The following is a description of a gene set: Human Gene Set: GOCC_CYTOPLASMIC_LATTICE Fibrous structures of the mammalian ooplasm that store ribosomes and maternal proteins in insoluble form to prevent their degradation, activation and nuclear transfer. studied in species Homo sapiens, and this is the list of marker genes: TLE6, OOEP, NLRP5, PADI6, KHDC3L